The following is a description of a gene set: The enlargement or overgrowth of all or part of an organ due to an increase in size (not length) of individual muscle fibers without cell division. In the case of skeletal muscle cells this happens due to the additional synthesis of sarcomeric proteins and assembly of myofibrils. Mouse Gene Set: GOBP_SKELETAL_MUSCLE_HYPERTROPHY studied in species Mus musculus, and this is the list of marker genes: Mtor, Mymk, Ar, Igfbp5, Myoc